The following is a description of a gene set: species: Homo sapiens Human Gene Set: GSE37605_TREG_VS_TCONV_C57BL6_FOXP3_IRES_GFP_DN The aim of this study was to quantify the impact of chimeric Foxp3-GFP protein on the Treg cell transcriptional program. Genes down-regulated in splenocytes from Foxp3-ires-GFP B6 mice: T reg (FOXP3+) versus T conv (FOXP3-). from publication Darce J, Rudra D, Li L, Nishio J, Cipolletta D, Rudensky AY, Mathis D, Benoist C (PMID 22579475), and this is the list of marker genes: ZKSCAN5, GPX4, NDUFA10, ARHGEF19, FAP, SNORD49B, GSTK1, CASP8, TMEM147, TUBB2A, CARS2, PMPCA, UQCC3, UROD, TRUB1 (NCBI Gene Id 170561), PLAG1 (PLAG1 zinc finger), TMEM212 (transmembrane protein 212), NUP35, EIF3K, RSPH6A, SSR2, IL2RA, ERCC8, RPL39, PEX12, FOXN3, IRX5, ANKRD45, RAB37, RPS9, TRIM13, PSMB1, RPL3, CD177, SLC35A4, PRPF31, TMEM81, EIF4E, RPP40, RING1, POLD4 (NCBI Gene Id 57804), RNF122, METTL6, USE1, BCKDHB, WASHC3, FIBP, RPL35A, SUMO2, RAB2B, DRG1 (developmentally regulated GTP binding protein 1), ATP5F1B, RPL11, MRC1, RANBP1, NOP16, LMO7 (LIM domain 7), PRKAB2 (protein kinase AMP-activated non-catalytic subunit beta 2), PEX19, PRCP, CD72, ECE2 (NCBI Gene Id 9718), PPA1, IMMP2L (NCBI Gene Id 83943), AGXT, DNAJC15, UXT, ADA, LYAR, CCDC28A, PDHX, RCN1, TMED4, NUP43, KRT2, CTRL, REXO2, EIF3H, GTF2F1, THUMPD2, FUNDC1, RPL38, BTRC, RASL10B, AK2, CTPS1, B3GALT4, UBXN11, AGER, COX7A2L, CRCP, PSME1, MRPS17, ECI2, GOLPH3L, MIR100, GPANK1, VPS4A, DPH5, SERPINI1, P2RY14 (NCBI Gene Id 9934), IGBP1, MECR, TRIML1, CCS, EXPH5, UBE2A, WNT8A, IDH3G, TIMM13, WDR70 (NCBI Gene Id 55100), SDHB, WDR43, MCEE, EMC8, GLRX2, ATP6V1F, DGUOK, EXOC1, HMGN2, TMEM175, RPLP2, ECSIT, PHYHD1, N6AMT1, KHK, HOXC6, SSR4, EEF1E1, AKAP8L, ING5, SCNN1G, NRROS, NSUN4 (NCBI Gene Id 387338), ABRAXAS2, GBA1, TMEM9, KSR2, RPS6KB2, EEF1AKMT1, NT5C3B, PM20D1, DTYMK, HMG20A, EXTL2, RPL36, SDF4, TADA3, MRPL49, SLC25A27, PRPS1